Given this list of marker genes SLC19A3, SLC35F3, SLC19A2, SLC47A1, SLC25A19, SLC22A1, SLC22A2, SLC44A4, here is a description of the gene set: Human Gene Set: GOBP_THIAMINE_TRANSPORT The directed movement of thiamine into, out of or within a cell, or between cells, by means of some agent such as a transporter or pore. Thiamine is vitamin B1, a water soluble vitamin present in fresh vegetables and meats, especially liver. species: Homo sapiens